Given this list of marker genes SLC24A4, SLC30A10, GHITM, SLC8B1, SLC8A3, SLC24A5, SLC24A2, SLC8A1, SLC24A3, SLC8A2, SLC24A1, LETM1, here is a description of the gene set: Human Gene Set: GOMF_CALCIUM_MONOATOMIC_CATION_ANTIPORTER_ACTIVITY Enables the transfer of a solute or solutes from one side of a membrane to the other according to the reaction: Ca2+(in) + cation(out) = Ca2+(out) + cation(in). studied in species Homo sapiens